The following is a description of a gene set: Genes down-regulated in hepatocellular carcinoma (HCC) cells with hepatic stem cell properties. BACKGROUND & AIMS: Cancer progression/metastases and embryonic development share many properties including cellular plasticity, dynamic cell motility, and integral interaction with the microenvironment. We hypothesized that the heterogeneous nature of hepatocellular carcinoma (HCC), in part, may be owing to the presence of hepatic cancer cells with stem/progenitor features. METHODS: Gene expression profiling and immunohistochemistry analyses were used to analyze 235 tumor specimens derived from 2 recently identified HCC subtypes (EpCAM(+) alpha-fetoprotein HCC and EpCAM(-) AFP(-) HCC). These subtypes differed in their expression of AFP, a molecule produced in the developing embryo, and EpCAM, a cell surface hepatic stem cell marker. Fluorescence-activated cell sorting was used to isolate EpCAM(+) HCC cells, which were tested for hepatic stem/progenitor cell properties. RESULTS: Gene expression and pathway analyses revealed that the EpCAM(+) AFP(+) HCC subtype had features of hepatic stem/progenitor cells. Indeed, the fluorescence-activated cell sorting-isolated EpCAM(+) HCC cells displayed hepatic cancer stem cell-like traits including the abilities to self-renew and differentiate. Moreover, these cells were capable of initiating highly invasive HCC in nonobese diabetic, severe combined immunodeficient mice. Activation of Wnt/beta-catenin signaling enriched the EpCAM(+) cell population, whereas RNA interference-based blockage of EpCAM, a Wnt/beta-catenin signaling target, attenuated the activities of these cells. CONCLUSIONS: Taken together, our results suggest that HCC growth and invasiveness is dictated by a subset of EpCAM(+) cells, opening a new avenue for HCC cancer cell eradication by targeting Wnt/beta-catenin signaling components such as EpCAM. Human Gene Set: YAMASHITA_LIVER_CANCER_STEM_CELL_DN from publication Yamashita T, Ji J, Budhu A, Forgues M, Yang W, Wang HY, Jia H, Ye Q, Qin LX, Wauthier E, Reid LM, Minato H, Honda M, Kaneko S, Tang ZY, Wang XW (PMID 19150350) species: Homo sapiens, and this is the list of marker genes: PRKCD, FMO3, GSTM4, ACSL5, NQO2, MAP2K2, SLC10A1, NR1I3, PPARGC1A, F9, ACSL3, CDKN2A, SAA4, GSTM1, ADCY3, APCS, MAOA, ABCG5, ABCB4 (NCBI Gene Id 5244), C8B, SOD1, RARG, C1R, ACSL1, ALDH8A1, C6, FKBP5, FABP5, RBP5, KLKB1, AOX1, HMGCR, UGT2B15, CYP8B1 (cytochrome P450 family 8 subfamily B member 1), HRG, SLC27A2 (NCBI Gene Id 8523), CES2, MAPK13, DNAJA4, ACSL4, GADD45A, GSTA1, MASP2, GADD45B, CYP3A4, CES1, ESR1, SULT2A1, APOC4, ALDH6A1, SNAI2, HNF4A, ALDH1L1, SULT1C2, ABCB1, CD14 (CD14 molecule), FMO4, APOA5, CYP7B1, MAP3K5, THBS1, GSTP1, KNG1, MASP1, UGT2B7, CYP1A2, F11, C8A, ABCB11, PIK3C2G, CYP7A1, SERPINC1, PIK3C3, NR1I2, CYP3A7, CYP2C8 (cytochrome P450 family 2 subfamily C member 8)